Given this list of marker genes PSMB9, FGG, ADRM1, STX4, PSMD6, CHUK, PSMB5, IKBKG, VAMP3, CALR, CD14, PSMD2, PSMA6, UBC, TAPBP, PSMB7, PSMA5, PSMC6, SEC61A2, SEC61A1, PSMA3, HLA-C, HMGB1, PSMD14, PSMD8, UBA52 (NCBI Gene Id 7311), HLA-F, HLA-G, TLR6, HLA-A, TLR4, PSMD11, PSMB8, S100A1, PSMB1, SEC22B, TIRAP, porB, SEM1, HLA-B, RPS27A, PSMA7, HLA-E, SNAP23, CD36, PSMC4, LY96, PDIA3, IKBKB, PSMA1, UBB, PSMB6, PSMA4, SEC61G, TLR1, S100A8, HLA-H, S100A9, FGB, TAP2, PSME2, PSMC5, PSMB2 (proteasome 20S subunit beta 2), PSMB4, PSMD12, B2M, PSMD1, PSMB10, PSMC2, PSME1, PSMD3, TLR2, PSMD7, VAMP8, BTK, FGA, TAP1, PSMC3, mip, PSMA2, MYD88, SEC61B, PSMD13, PSMC1, PSMB3, here is a description of the gene set: species: Homo sapiens part of: Antigen processing-Cross presentation Reactome Pathway: ER-Phagosome pathway The other TAP-dependent cross-presentation mechanism in phagocytes is the endoplasmic reticulum (ER)-phagosome model. Desjardins proposed that ER is recruited to the cell surface, where it fuses with the plasma membrane, underneath phagocytic cups, to supply membrane for the formation of nascent phagosomes. Three independent studies simultaneously showed that ER contributes to the vast majority of phagosome membrane. The composition of early phagosome membrane contains ER-resident proteins, the components required for cross-presentation. This model is similar to the phagosome-to-cytosol model in that Ag is translocated to cytosol for proteasomal degradation, but differs in that antigenic peptides are translocated back into the phagosome (instead of ER) for peptide:MHC-I complexes. ER fusion with phagosome introduces molecules that are involved in Ag transport to cytosol (Sec61) and proteasome-generated peptides back into the phagosome (TAP) for loading onto MHC-I. <br>Although the ER-phagosome pathway is controversial, the concept remains attractive as it explains how peptide-receptive MHC-I molecules could intersect with a relatively high concentration of exogenous antigens, presumably a crucial prerequisite for efficient cross-presentation.